The following is a description of a gene set: Human Gene Set: GSE4142_NAIVE_VS_GC_BCELL_UP In order to better understand the factors that regulate B cell differentiation upon exposure to antigen, we compares global gene expression profiles from naive B cells with antigen-specific plasma, germinal center, and memory B cells after immunization with the T-dependent antigen, NP-CGG. The memory B cell-enriched transcripts were then compared with memory T cell-enriched and hematopoietic stem cell-enriched transcripts in order to generate a transcriptional profile of self-renewal within the hematopoietic system. from publication Luckey CJ, Bhattacharya D, Goldrath AW, Weissman IL, Benoist C, Mathis D (PMID 16492737) species: Homo sapiens Genes up-regulated in B lymphocytes: naïve versus germinal center., and this is the list of marker genes: N4BP1, ZFYVE1, BMAL1 (basic helix-loop-helix ARNT like 1), CDS2, WNT5B, YPEL1, DOCK2, CCDC80, TEX47, PRR5L, SSBP4, ATP1B1, TMEM14C, NOVA1, UBD, MYH9, KLF2 (NCBI Gene Id 51713), RIT1, ALPK2, ITPR3, OSBPL6, COL15A1, NT5E, KLRD1, TBC1D4, OSBPL1A, TMEM131, BLCAP, LRRC8D, MOS (MOS proto-oncogene, serine/threonine kinase), SOX4, KRTAP7-1, TRIM63, UCHL3, EEF1AKMT1, ATXN10, SPAM1, EPB41L2, MDFIC, ITGB2, EIF2AK3, MLLT6, UBXN4 (NCBI Gene Id 23190), NIPAL1, B4GALNT2, PRR16, ULK1, KCNK6, ZBTB18, KLHL8, SNX12, WWP1, MYOF, APOL6, CHD3, CLOCK, MUC4, PHKG2, POU6F1 (NCBI Gene Id 5463), PHF14, LSM7, MYOZ1, NTAQ1, PIK3CG, JTB, SARDH, SLC44A1, STIM2, MRPS5, DNER, SNF8, B4GALNT4, INTS4, C11orf68, NUTF2, FTH1, RFX8, IL17RE, CDKL3, DANCR, CERK, BAZ2B, ZNRF1, DIAPH2, TATDN2, INO80E, RIN2 (NCBI Gene Id 54453), FARP2, CTNND1, APLP2, PXMP2, CHKB, QSER1, FFAR4 (free fatty acid receptor 4), VCL, SYT13, ZNF579, GRN, EPC2, UMODL1, CXCR5, MIDEAS, CCN1, IL18R1, USP46, CYP1A1, TSPAN7, UCHL1, HAVCR1, RAB24, GPR155, FOXF2, TRPT1, SLC4A11, TLR3, ULK3, STAB1 (stabilin 1), ARHGAP24, GP1BA, FAM217A (family with sequence similarity 217 member A), SASH3, SSH2, GSAP, AKAP5, CDK5R2, C16orf89, MOB3B, RAB3IP, NTN1, WDR47, PKN1, RGL1, H3C14, STK19 (NCBI Gene Id 8859, serine/threonine kinase 19), AP1S2, MAGI3, TSPAN2, CRMP1, LHX8, KLF10, DCUN1D4, TNFRSF13B, BCL2L12, NEFL, LHFPL2, CHPF2, SKIL, TTC21B, ROR2, ATOSB, RORC, ZC3H12C, TMEM176A (transmembrane protein 176A), GABARAPL1, SMAD7, TTPA, CCL7, DDX23, IYD, FBXL7, KBTBD7, NPR2, PRR13, GREM1, KIFC3, ULK2, AFF1, FGD3, REXO4, RASA1, ANKRD45, TXK, TMEM176B, PLTP, ADAMTS4, PRNP, CNP, TDRD9, VWA3A, TBC1D14 (TBC1 domain family member 14), RAB3B, CTXN2, DIPK2A, RNF39, SBK1, MPEG1, CAMK1D, SEMA3D, B3GALNT1, ALG5, TDRKH, TRIR, ARHGAP45, MYO3B, MGAT5, TACC1, CARD6, FAM20A, SESTD1